The following is a description of a gene set: The dense covering of microvilli on the apical surface of an epithelial cell in tissues such as the intestine, kidney, and choroid plexus; the microvilli aid absorption by increasing the surface area of the cell. Human Gene Set: GOCC_BRUSH_BORDER species: Homo sapiens, and this is the list of marker genes: SLC34A2, ACTN1, CAPZB, PDZK1, SLC3A1, MME, MYL6, SLC22A5, EZR, PEX19, MTTP, SLC19A1, SNX5, MYH10, FLNB, AQP1, HSP90AA1, CAPZA2, ACTB, ACTN3, SI, SLC6A19 (solute carrier family 6 member 19), SLC28A2, AQP8, VIL1, PLB1, B4GALT1, SLC26A6, SCART1, SLC38A2, PLEC, DCXR, SLC2A2, USH1C, MYO1A, SLC28A1, CA4, CORO2A, CDHR2, MYO1C, SLC6A18, CYBRD1, FOLR1, ABCB1, NHERF1, KCNK1, FLII, GNA12, PRKCI, SHANK2, ACE2, CLTRN, MFSD10, SCIN, MYL12B, SLC27A4, MYH14, SLC15A1, SLC26A3, MYO1E, SLC5A1, ITLN1 (NCBI Gene Id 55600), SLC17A3, PLS1, SLC7A11, CLIC1, SLC5A6, TRPM6, CUBN, LRP2, CDHR5, VCL, SLC20A2, SOAT2, EPS8, ACTR3, SLC7A9, SLC11A2, SLC34A3, ANKS4B (NCBI Gene Id 257629), CD36, RALGDS, ESPN, ENPEP, SLC28A3, MYO7B, LIMA1, SLC46A1, NHERF4, ITPR3, SLC9A3, GNA13, ADD3, SLC17A4, NPPA, TMPRSS15, SLC26A4, PLD2, ABCG2, ATP6V0A4, AMN, DRD5, MYH9 (NCBI Gene Id 65212), LCTL, SLC22A12, DNM1L, MYO1B, MYO1D, SLC34A1 (solute carrier family 34 member 1)